Given this list of marker genes Klf10, Hes1, Taf5l, Raf1, Six2, Sall4, Kat6a, Ldb2, Ski, Vps72, Nog (noggin), Lbh, Zfp36l2, Tal1, Nr5a2, Med30, Stat3, Tcf7l2, Pou5f1, Tbx1, Apc, Prdm16, Yap1, Zhx2, Taf6l, Hmga2, Med12, Wnt9b, Med15, Panct2, Wnt7a (wingless-type MMTV integration site family, member 7A), Smo, Myc, Med10, Cdkn2a, Nodal, Gata2, Ascl2, Tfap2c, Klf4, Spi1, Sfrp1, Nipbl, Elf5, Med24, Braf, Pramel7, Sall1, Sox9, Bcl9l, Med6, Rbpj, Kit, Pla2g2a, Pax8, Med17, Med27, Fgfr3, Erdr1, Cdx2, Lrp5, Nkap, Bmpr1a, Tcf7l1, Fgf10, Sox4, Bcl9, Med28, Bmp7, Nanog, Rif1, Tcl1, Lig4, Smc1a, Nr2e1, Esrrb (NCBI Gene Id 26380), Med7, Trp63, Gsdma3, Med21, Med14, Pax2, Sox2, Ldb1, Lif, Rest, Hnf1b, Cul4a, Vangl2, Fgf4, here is a description of the gene set: studied in species Mus musculus Any process by which an organism retains a population of somatic stem cells, undifferentiated cells in the embryo or adult which can undergo unlimited division and give rise to cell types of the body other than those of the germ-line. Mouse Gene Set: GOBP_SOMATIC_STEM_CELL_POPULATION_MAINTENANCE